Given this list of marker genes Oxsr1, Ednrb, Maged2, Nherf1, Klhl3, Ednra, Pon3, Umod, Kcnj1, Atp6v1b1, Kcnq1, Stk39, Slc12a3, Wnk4, Guca2b, Edn1, here is a description of the gene set: The directed movement of sodium ions (Na+) by the renal system. Mouse Gene Set: GOBP_RENAL_SODIUM_ION_TRANSPORT species: Mus musculus